Given this list of marker genes Slc35a1, Slc35d2, Slc35a3, Slc35d1, Slc35c1 (solute carrier family 35, member C1), Slc35b1, Slc35d3, Atp2a1 (ATPase, Ca++ transporting, cardiac muscle, fast twitch 1), Slc35b4, Slc35a5, Slc35a2, Tmem241, Slc35e3, here is a description of the gene set: Enables the transfer of a nucleotide-sugar from one side of a membrane to the other. A nucleotide-sugar is any nucleotide in which the distal phosphoric residue of a nucleoside 5'-diphosphate is in glycosidic linkage with a monosaccharide or monosaccharide derivative. species: Mus musculus Mouse Gene Set: GOMF_NUCLEOTIDE_SUGAR_TRANSMEMBRANE_TRANSPORTER_ACTIVITY